Given this list of marker genes Kcnd2, Gabbr1, Gabra2, Fgf7, Septin11, Nrxn1, Atp2b2, Ap3m2, Lrrtm4, Drd2, Phb2, Cacna2d1, Strn4, Nlgn4l, Gabbr2, Sv2a, Syt7, Rims1, Gabrg3, Iqsec3, Gap43, Pclo, Igsf9b, Dtnb (dystrobrevin, beta), Rps27, Gabrr2, Cbln4, Fgf22, Gnao1, Slc32a1, Gabrr3, Adra1a, Nptn, Nrxn3, Cdh10, Pik3c3, Mkln1, Npy5r, Erbb4, Gabre, Clcn3, Drd3, Shroom4, L1cam, Gabrb3, Dag1, Baiap3, Rac1, Lpar1, Cacna2d2, Oprm1, Adra2a, Nxph4, Mdga2, Acan, Atp2b3, Gabrg2, Nrg2, Ctbp2, Cntnap4, Slc6a1, Drd1, Nxph1, Lrrtm1, Phb1, Clstn1, Disc1, Kcnc2, Nr3c2, Camk4, Rps27rt, Slc6a6, Clstn3 (calsyntenin 3), Atp2b1, Zdhhc5, Gabra1, Arfgef2, Trpv1, Gabrr1, Git1, Slc6a17, Epha3, Kctd12b, Efna5, Rims2, Pak1, Sh3kbp1, Insyn1, Wnk1, Lhfpl4, Grip1, Gad2, Ctbp1, Nrg1, Npy, Nlgn2, Gabra6, Gphn, Gucy1a1, Cck, Cxadr, Ptpro, Mdga1, Clptm1, Plcb1, Dmd, Gad1, Arhgef7, C1qbp, Slc4a10, Ncan, Cspg5, Kcnd3, Cacna2d3, Snap23, Cdh13, Cacna1e, Bcan, Grm7, Cnr1, Grm8, Bsn, Slitrk3, Gabra5, Insyn2a, Abhd6, Kif5c, Hap1, Sema7a, Atr, Pcdh17 (protocadherin 17), Htr1a, Praf2, Lrfn4, Cit, Glrb, Nlgn3, Calb1, Itpr1, Gabrb1, Lamp5, Sema4d, Gabrd, Ctsd, Slc6a11, Sst, Slitrk1, Cnrip1 (NCBI Gene Id 77064), Drd4, Kif2a, Lrfn5, Kctd12, Sumo2, Erc2, Magi2, Arhgef9, Glra2, Erc1, Nbea, Lrrtm2, Grid1, Fus, Cntn5, Gabrb2, Ogt, Gabarap, Slitrk2, Flot1, Gabra3 (NCBI Gene Id 14396), Gabra4, Rps6-ps4 (ribosomal protein S6, pseudogene 4), Rps6, here is a description of the gene set: A synapse that uses GABA as a neurotransmitter. These synapses are typically inhibitory. Mouse Gene Set: GOCC_GABA_ERGIC_SYNAPSE species: Mus musculus